The following is a description of a gene set: Genes containing one or more binding sites for (HMCES) in their promoter regions (TSS -1000,+100 bp) as identified by GTRD version 20.06 ChIP-seq harmonization. Human Gene Set: HMCES_TARGET_GENES studied in species Homo sapiens from publication Yevshin I, Sharipov R, Kolmykov S, Kondrakhin Y, Kolpakov F (PMID 30445619), and this is the list of marker genes: MT-TQ, SNORA68, MT-ND4, MT-TC, MT-CYB, MT-ND6, MT-TY, CBLN3, MT-TA, MT-ND4L, KHNYN, MT-TW, MT-CO1, SUPT20H, CNTLN, MT-ND3, KIAA0513, TBL1XR1-AS1, MT-TG, MT-TN, RAD54B, MT-TR